The following is a description of a gene set: Mouse Gene Set: MIR_7031_5P Genes predicted to be targets of miRBase v22 microRNA mmu_miR_7031_5p in miRDB v6.0 with MirTarget v4 prediction scores > 80 (high confidence targets). studied in species Mus musculus from publication Chen Y, Wang X (PMID 31504780), and this is the list of marker genes: Rrp8, Mybl1, Efcc1, Lzts3, Pcmtd2, Prph2, Brk1, Hps3, Pcyt1a, Hmbox1, Kcnip1, Slc38a7, Cacna1g (calcium channel, voltage-dependent, T type, alpha 1G subunit), Slc9a5, Arpc5, Ipmk, Zfhx3, Rasl12, Snx30, Sec14l3, Agpat2, Net1, Sprr2a2, Ak4, Tlnrd1, Hlcs, Vmn2r37, Serpina3b, Tctn1, Arhgdib, Mapk10, Arfgef2, Slc43a2, Thsd7b, Tspan9, Tmem234, Hoxb1, Cyp8b1, Vmn2r42, Stard3nl, Vgll3, Wnt7a, Hapstr1, Klk4, Polr3b, Gnb1l, Sprr2a1, Ammecr1l, Fzd3 (frizzled class receptor 3), Zmiz1 (zinc finger, MIZ-type containing 1), Rem1, Cog5, Amotl1, Ppp2r5c, Dusp16, Aldh16a1, Prkag3, Tenm3, Arpp21, Per2, Ar, Gabpa, Mrpl35, Snx4, Klf9 (Kruppel-like transcription factor 9), Kif1b, Mras, Fli1, Bpnt2, Atad2b, Rsf1, Shank2, Gpr45, Bhlhb9, Fahd2a, Serinc5, Tmem154, Armc10, Map1b, Cyp2j13, Dcaf12l2, Cradd, Usp11 (NCBI Gene Id 260307), Gjc3, Mtcl2, Phlpp2, Peg10, Pank3, Slc8a1, Cpne6, Lhx6, Shisal1, Rhoq, Musk, Celsr1, Fkbp3, Itpripl2, Klhl31, Maml1, Pbsn (probasin), Nexmif, Prmt8